The following is a description of a gene set: Mouse Gene Set: GOCC_CHLORIDE_CHANNEL_COMPLEX species: Mus musculus An ion channel complex through which chloride ions pass., and this is the list of marker genes: Clcc1, Cftr, Ttyh2, Gabrr1, Best2, Gabrr2, Ttyh1, Gabra2 (gamma-aminobutyric acid type A receptor subunit alpha 2), Clic4, Gabra1, Glra1, Clic1, Gabrg1, Gabra3, Gabrg2, Best3, Glrb, Ano1, Slc26a6, Clic5, Best1, Slc17a6, Clcn7, Gabra5, Ttyh3, Clcnkb (chloride channel, voltage-sensitive Kb), Mfsd8, Gabrp, Clcn1, Ano2, Glra2, Glra4, Clic3, Gabrq (gamma-aminobutyric acid type A receptor subunit theta), Gabrb1, Gabrb3, Gabrb2, Pacc1, Gabrd, Gabra6, Gabra4, Ano6, Cldn17 (claudin 17), Cldn4, Ostm1, Gabrg3, Clcnka, Slc17a8, Glra3, Clcn2, Slc17a7, Clic6